The following is a description of a gene set: Human Gene Set: HP_EROSION_OF_ORAL_MUCOSA Loss of the superficial layer of the oral mucosa usually resulting in a shallow or crusted lesion. Erosion of oral mucosa studied in species Homo sapiens, and this is the list of marker genes: KRT5 (keratin 5), IL12A, LYN, LAMA3, BRAF, IRF5, UBAC2, G6PC3, RORC, STK4, HLA-DQA1 (NCBI Gene Id 7946), CD40LG, SPP1, HYOU1, RIN2, MEFV, CYBC1, IL21, IL10, MECP2, CTLA4, IL17RC, C4A, PTPN22, WDR1, NRAS, PDCD1, RIPK1, KIAA0319L, ADA2, FAS, COL7A1, NLRP12, SAT1, IL23R, KLRC4, CASP10, MAP2K1, CARMIL2, LAMC2, SYK, SBDS (SBDS ribosome maturation factor), DOCK11, LAMB3, DSG3, NOD2, BANK1, TNIP1, IL10RA, NLRP3, PXK, DNASE1, SLC37A4, MMP1, TNFSF4, TLR4, EFL1, TICAM1, FASLG, IL12A-AS1, IGHG1, ERAP1, SASH3, SEC61A1, MALT1, CR2, HLA-B, CD27, GFI1, SLC46A1 (NCBI Gene Id 113235), PRKDC, CCR1, ORAI1, TLR7, SRP19, JAZF1, DNAJC21, TLR8, NCF4, FCGR2B, CLPB, KRT14, IFNGR1, TCIRG1, ELF4, RELA, DCLRE1C, ETS1, HLA-DRB1, CAT, UBE2L3, IL7R, RNF125, ELANE, MVK, ITGAM, HLA-DQB1, SLC19A1, CEBPE (NCBI Gene Id 1053), C1QB, STAT4 (NCBI Gene Id 6775), TREX1, C4B, IL6, BLK, FCGR3B, IRAK1, TNFAIP3